The following is a description of a gene set: Human Gene Set: GOBP_RESPONSE_TO_HYDROXYUREA Any process that results in a change in state or activity of a cell or an organism (in terms of movement, secretion, enzyme production, gene expression, etc.) as a result of a hydroxyurea stimulus. studied in species Homo sapiens, and this is the list of marker genes: DDI1, NSMCE3, SPIDR, DDX11, TREX1, BLM, KAT7 (lysine acetyltransferase 7), RAD51, TIMELESS, ATRX, RTF2, DDI2